Given this list of marker genes NQO2, CYP1A1, UQCRH, UQCRFS1, UQCRFS1P1, UQCR10, LACC1, CYC1, UQCRC1, MT-CYB, here is a description of the gene set: studied in species Homo sapiens Human Gene Set: GOMF_OXIDOREDUCTASE_ACTIVITY_ACTING_ON_DIPHENOLS_AND_RELATED_SUBSTANCES_AS_DONORS Catalysis of an oxidation-reduction (redox) reaction in which a diphenol or related substance acts as a hydrogen or electron donor and reduces a hydrogen or electron acceptor.